Given this list of marker genes SORBS1, KCNC4, RALY, VNN1 (NCBI Gene Id 8876), TTC39A, IL20, SUN3, TMC7, MAB21L1, ITGA9, FREM2, TMEM213, KCND2, TSPAN8, TTN, RTL3, VXN, BPIFB2, NKAP (NFKB activating protein), EGF, MAP3K1, IL2RA, SPON1 (spondin 1), LRRN4, RGR, PDCL2, KHDC4, HNF4G, ENSG00000285566, HECTD4, MAPK4, TIAM2, AGRN, AMTN, TRIM31, DNAJC7, PHACTR4 (NCBI Gene Id 65979), TSPAN7, CASQ1, NLRP4, DENND5B, SNHG11, TSPAN12, IL1RAPL2, RPS3A, CD160, RNF152, SRSF12, ZFC3H1, CPXM2, THBS2, SHD, RSPH4A, WNT3, ALX1, KRT2, L1TD1, SCLT1, CLK1, GIMAP4, CSRNP3, TMEM204, PEBP1, LBP, GPR26, GZMM, DGKB, ABCA8, CXCR6, ANO9, ST14, GLG1, VEPH1, H3C7, SERPINC1 (serpin family C member 1), CLIC3, PLLP, SMIM1, MS4A1, CCDC85B, CYFIP1, NCAM2 (neural cell adhesion molecule 2), RAB39B, EIF4G2, NBEA, ZNF322, CHCT1, RPE65 (retinoid isomerohydrolase RPE65), NEAT1, TRIM6, DPYD, RNF133, FOXF2, BBS12, KRT8, NCR1, CA12, ZNF169, MYL1, LYPD3, ATP13A4, ENSG00000267882, STAC, RBM4B, SEPTIN2, AMBN, TMEM200A, SHE, LRRTM2, CD164L2, LRP2, HAO2, BMP7, GXYLT2, ZBTB32, ACTR3B, PPP1R3C, TBC1D4, CDH22, DNAH8, IRF4, EPS15L1, ARPP21, MARF1, RPL14, MAPK10, YTHDC1, TSTD1, SLC6A11, IDS, ELANE, CNTNAP2, CHRM4, WDR70, PLCH1, RSPO2, ESR2, MMUT, INA, H3C4, GJB5, UBE3D, ZBTB5, CEP126, TPT1, NR6A1 (NCBI Gene Id 2649), PRKAA2, SERPINI2, CCDC171, EREG, VCPIP1, AQP5, PABPC1L, TMEM72, RBM6, LGI1, NR1I2 (NCBI Gene Id 8856), PDYN, KCNK1, MIR9-2HG, CAGE1, HOXD8, SLC6A1, VTCN1, NADSYN1, TDRD12, AMOT, ADAMTS18, SERBP1, CWC22, ZNF423, PON1, GJC3, FAM174B, GABRA1, EFCAB14, LRGUK, PCBP1, OR2S2, PROX2, IL13RA2, SCGB3A2, CD34, LRRC69, STK4 (NCBI Gene Id 6789), GDPGP1, PRDM16, EXPH5 (exophilin 5), FOXD4L1, LRRC73, FBXO43, TOR3A, DCST1, NPY1R, SIT1, UCN2, PROS1, SLC15A4, DHX57, UBASH3A, here is a description of the gene set: Genes down-regulated in B lymphocytes treated by anti IgM for 1h: wildtype versus MAP3K7 knockout. Human Gene Set: GSE41176_WT_VS_TAK1_KO_ANTI_IGM_STIM_BCELL_1H_DN species: Homo sapiens The activation signaling of transcription factor nuclear factor-kB (NF-kB) plays central role for immune system. One of key kinase mediating this pathway is TAK1 in adaptive and innate immunity. However, role of TAK1 in B cell receptor signaling is still unclear. To know effects of TAK1-deletion on the gene expression induced by anti-IgM, we performed the time course analysis in comparison of wild type with TAK1-deleted splenic B cells. from publication Shinohara H, Behar M, Inoue K, Hiroshima M, Yasuda T, Nagashima T, Kimura S, Sanjo H, Maeda S, Yumoto N, Ki S, Akira S, Sako Y, Hoffmann A, Kurosaki T, Okada-Hatakeyama M (PMID 24833394)